Given this list of marker genes FYN (FYN proto-oncogene, Src family tyrosine kinase), MAFF, GPD2, MMP12 (matrix metallopeptidase 12), GP1BA, CTSC, DPP4, CALM3, DGKG, ZFPM2, GZMK, LCK, KIF2A, RHOG, CD46, MMP8, CSRP1, ADRA2B, APOC1, HPCAL4, CCL5, GNAI3, PIK3CG, GNB2, PRSS3, SPOCK2, NOTCH4, PCSK9, RASGRP1, LYN, SERPINE1, OLR1, CD55, BRPF3, HSPA5, CPQ, ME1, PSEN1, RBSN, DUSP5, CTSB, CALM1 (NCBI Gene Id 801), C4BPB, MT3, SERPINA1, MMP13 (matrix metallopeptidase 13), CA2, FCER1G, GRB2, DOCK4, CASP5, L3MBTL4, CD40LG (NCBI Gene Id 959), SCG3, ITIH1, C9 (complement component 9), CASP10, MSRB1, PREP, SRC, PIM1, VCPIP1, PRCP, DOCK10, USP16, PLA2G7, GNB4, KCNIP2, CASP1, F7, C3, PLG, CFB, CLU, TIMP1, LCP2, FDX1, KLKB1, C1QC, CASP9, CTSH, LAMP2, USP8, F10, F3 (coagulation factor III), XPNPEP1, USP14, PLEK, PLSCR1, PIK3R5, TNFAIP3, ADAM9, S100A13, CR1, GNG2, CXCL1, GNGT2, CD36, PCLO, JAK2, LGMN, CTSD, ANXA5, ERAP2, PHEX, SH2B3, GATA3, PSMB9, C1R, COL4A2, SERPINC1, CDK5R1, PLAUR, SERPING1, RNF4, GZMA, CP, DOCK9, CBLB, PLAT, APOBEC3G, STX4, DGKH, HNF4A, TFPI2, GZMB, PDGFB, RABIF (NCBI Gene Id 5877), GP9, LGALS3, CASP7, ATOX1, GNAI2, CDA, CFH, PPP4C, DUSP6, ANG, KYNU, FCN1, PPP2CB, CR2 (NCBI Gene Id 1380), MMP14, CTSS, HSPA1A, S100A9, CTSL (NCBI Gene Id 1514), MMP15, PLA2G4A, ITGAM, KCNIP3, C2, GCA, IL6, ZEB1, CASP3, CDH13, TMPRSS6 (transmembrane serine protease 6), CD59, CTSO, GMFB, PRSS36, PRDM4, AKAP10, TIMP2, CTSV, IRF2, C1QA, DYRK2, PRKCD, FN1, SERPINB2, PIK3CA (phosphatidylinositol-4,5-bisphosphate 3-kinase catalytic subunit alpha), APOBEC3F, CASP4, KLK1, LTF (lactotransferrin), CPM, CEBPB, IRF1, ACTN2, F2, LIPA, PDP1, F5, LTA4H, WAS, PFN1, RCE1, SIRT6, EHD1, RAF1, LRP1, IRF7, C1S, S100A12, LAP3 (leucine aminopeptidase 3), F8, USP15 (ubiquitin specific peptidase 15), APOA4, here is a description of the gene set: Genes encoding components of the complement system, which is part of the innate immune system. species: Homo sapiens from publication Liberzon A, Birger C, Thorvaldsdóttir H, Ghandi M, Mesirov JP, Tamayo P (PMID 26771021) Human Gene Set: HALLMARK_COMPLEMENT